Given this list of marker genes ATG4C, IL20RA, GARS1, CCNDBP1, RAD51 (NCBI Gene Id 5888), LRRC23, JUN, VIPAS39, ALG1, TEAD4, PRPF40B, TTI1, CCDC192, RPS9, TMEM87A, ENSG00000260830, MIR200CHG, ZZZ3, NFYA, ATP6V0D1, NOP2, COPB2, S100A10, PPWD1, CCDC71, USP48, ATP6V0D1-DT, UQCR11, RPL4, MPG, RCC1, CENPK, AHSA1, SF3B3, CDK5, FAM114A2, ZWILCH, PLAC8, PPP1R13L, POU6F1, ACTMAP, PPM1D, INO80, NUP42 (nucleoporin 42), SMIM12 (small integral membrane protein 12), POLR2H, GANC, ZFYVE26, TIMM9, H4C16, CNP (NCBI Gene Id 1267), CCNH, MED20, MATCAP1, OARD1, RHBDF1, PTGES3, GALNT12, CAPZA2, HSP90B1, NFU1, RPL32, BYSL, SDR39U1, CYP4F11, PRDM1, FASTKD1, RNY1, PPFIA3, TPRXL, CEP152, KIAA0586, ZBTB45, NDC80, HBP1, VMAC, TRGV1, JUN-DT, TJP1, MIR4512, DHX38, ZNF117, POLR1G, CERT1, TXNL4B, ABALON, KNL1, HOXB6, COPS4, NOCT, POLH, SCAF11, SNORA7A, DMXL2 (Dmx like 2), INTS2, RPRD1B, LINC01269, NDUFA11, ERV3-1, H2BC8, SNHG3, RPL28, STPG1, H2AC8, LSG1, DDR1, POLK, STYK1, XPO5, HSPA13, CYTIP, STAM-DT, EIF4H, ABHD2, KAT6B, STK40, SART1, S100A11, ENSG00000277020, EFCAB5, COG4, GHET1, STAT6, here is a description of the gene set: species: Homo sapiens from publication Yevshin I, Sharipov R, Kolmykov S, Kondrakhin Y, Kolpakov F (PMID 30445619) Genes containing one or more binding sites for (HOXC13) in their promoter regions (TSS -1000,+100 bp) as identified by GTRD version 20.06 ChIP-seq harmonization. Human Gene Set: HOXC13_TARGET_GENES